Given this list of marker genes CNN1, MADD, LHX1, SLC9A7, ARHGAP6, HYCC2, WBP1L, NCKAP5, FNDC7, ATF3, ADGRL1, CREB3L3, GJB2, RAB3A, CNTN2, CIAO2A, PLPPR2, IDH3A, HP, CPNE1 (NCBI Gene Id 8904), NREP, TGM6 (NCBI Gene Id 343641), FBLN5, CDH6, OGDHL, OXA1L, PHB1, CLIC1, ARRDC1-AS1, BCKDHA, CDH13, RB1CC1, STAC2, ST8SIA5, NAE1, TPM3, TRMT10A, NRSN2, BTG2 (NCBI Gene Id 7832), CIART, SIK3, CALCB, SLC29A2, FOXD3, MTUS1, SGIP1, ANKRD28, CREB3, DENND2B, DUSP3, DIRAS1, FNDC5 (fibronectin type III domain containing 5), RUNX1T1, AFG3L2 (NCBI Gene Id 573970), SLC24A4, TTL, SELENOI, BZW2, ZMAT4 (NCBI Gene Id 79698), DAZAP1, KIRREL3-AS3, ACKR3, IL17A, PLA2G2E, FANCD2 (NCBI Gene Id 2177), MTTP, PITX2, COMTD1, TSC22D2, PPP1R16B, TMEFF1, HPN, KCTD6, RTN4R, CHCHD4, TRPM4, RFX5, ABR, TMEM50B, RPS14, ATP6V1A, TMEM71, ATP5F1C, COMMD3, JARID2, CFP, RS1, G0S2, VPS26C, SCUBE3, SIRPA, SLC31A2, MED13, FHDC1, INCA1, CHAT, TCF7, MARCKSL1, KCNE5, GRID2, SART3, NYAP1, SF3B4, WTAP, GRIA4, PRMT1, GEMIN7, HRH3, AMY2A, SDHD, ATP6AP2, BPNT2, BEND6, MREG, MYOM3, MFN1, CCNB1IP1, CSNK2A1 (NCBI Gene Id 1457), LINC00472, JPH2, EEF1G, TTC19, MEF2D, FSTL3, CCDC38, KCND3, MITF, TENM3-AS1, CNOT9, BMPR1B, PKN1, WNT4, PIEZO1, ESRRG, TIMM8B, FAM193B, PCSK2, CDKN1A, SH3RF2, HOXC13, TRMT2A, MLX, ATP1B1, HNF1B (HNF1 homeobox B), CYP21A2, AIFM3, UCHL1, MLST8 (MTOR associated protein, LST8 homolog), CDK14, BTBD3, TAB3, BNC2 (NCBI Gene Id 54796), VEZF1 (vascular endothelial zinc finger 1), MEIS2, PRDM9, VEGFA, HIPK2, SOX12, ANGPT1, RBPMS, ABHD17B (abhydrolase domain containing 17B, depalmitoylase), C1QTNF7, PACS1, SLC30A3, SLC22A11, CALHM1, MYL3, ZMAT3, SPATA32, NAA50, CYP39A1, ZSWIM1, TAFA1, ADAMTS14, CLTC, HIBADH, ERRFI1, ABHD8, RANBP1, CALCA, FAM81A, MRPL14, PPP3CC, TAGLN2 (transgelin 2), DAAM1, MAP1B (microtubule associated protein 1B), TMEM187, SAMD14, ADGRA2, DNAJB13, PPA1, ZFYVE9, SPAG8, RCOR2, RBMX, SMIM3, TPPP3, PRKAB1, SOD3, ACAT1, DNAJB8, ARHGAP18, EFNB2, HOXA5 (homeobox A5), NPAS2, MRPL47, KMT2E, SPATA3, RAPH1, LINC00487, RBM4B, MBD6, EEF1A2, ADAMTSL3, GABBR2, CRISPLD2, DCTN2, CCDC69 (NCBI Gene Id 26112), CHCHD10, ID3, COX5B, RAB6B, ALPG, FGFR3, MRPL2, PRLR, MYADM, OSM, POLR3D, DLX4, SOX4, UBQLN3 (ubiquilin 3), ZNF143, TMEM35A, SH3GL2, TNNI1, PACSIN1, C1orf116, NFIL3, RASGRP2 (RAS guanyl releasing protein 2), VTA1, LRCH4, SOCS2, TMEM135, SYNGR1, PRDM16, MROH5, VASP, SLITRK1, AAMP, TLX2, AGPS, NDFIP1, SUN5, PPM1B, TAOK2, DNAJC27 (NCBI Gene Id 51277), PKNOX2, HOXA3, ODAD3, C6orf47, C12orf50, ARX, MASP1, GTF2IRD1, RGS3, PPP2CA, MAPRE1, SNPH, SLC25A13 (solute carrier family 25 member 13), AK2, ASXL2, KCNK1, ACO2, SV2A, LCA5, SLC37A2, DNM1, YTHDF2, CSMD3, RXFP4 (relaxin family peptide/INSL5 receptor 4), APBA2, SEMA3F, GABRG2, MED26 (NCBI Gene Id 9441), PHF5A, NNAT, LDB3, NFIX, ARL8A, FSTL1, AP1S2, MFF, PNKD, RHOT1, FXYD1, MTX2, WDR82, ODF1, TBX6, RPE (ribulose-5-phosphate-3-epimerase), SLC27A4, ABCC5, TMCC1, ITPKA, IFRD1, PITPNM1, EWSAT1, MAP4K3, DOLK, AGAP2 (NCBI Gene Id 9809), AP1B1, HOXD3, RPP25L, SLC25A5, DNAI7, MYH13, SLCO3A1, ENSG00000291228, KIN, PSD3, CEND1, SEMA7A, TMEM196, NXPH4, SPATA31G1, EMC8, NEUROG2, TP53BP1, ST3GAL1, ATP5MK, KIF6, COA8, TF, GOT1, OAT, XPR1, PAX6, MRPL12 (mitochondrial ribosomal protein L12), ESAM, SPMIP6 (sperm microtubule inner protein 6), CHD2, MLLT6 (NCBI Gene Id 4302), ARHGEF12, ADAMTSL5, NDUFB5, GOLGA4, RTN3, UQCRC2, RNF4, DLX1, PPP1CB, TRAP1, ETV6 (NCBI Gene Id 4348), PRKCSH, MSI2, PHACTR3, UBE2D3, BAG5, EXTL2 (NCBI Gene Id 2135), LTBP3, NUFIP2, NTMT1, HCN1, HSALR1, ARHGEF38, ATP5MC3, GOSR1, KLC4, GRIK3, DIPK1B, FAM170A, CCDC9B, CDH20, ZFP91, R3HDM2, COPS7A, HMGB3, PDZK1, RPS6KA5, COX4I1, MPP2 (MAGUK p55 scaffold protein 2), ERGIC1, TBC1D22A, RAB11FIP5, SENP1, CLC, POU3F2, DTNB, CDC42EP1, DDIT3, S100A5, HS6ST2, SYT17, FHL3, ALDOA, DOK4, ILRUN, MEF2C, PALS2, CNTN6, TMEM161B, RIMS2, PANK1, NTNG2, TOMM70, MT-CO1, RTKN, KLHL41, AKAP1, EIF4E, BCL6, OR3A2, AUH, APP, THPO, PFN1, RNF121, GPATCH2L, AQP7, TUBB4A, DNAJC11, ANO4, RHO, ABL1, ZNF644, CLIC4, BAIAP2L2 (NCBI Gene Id 80115), TMEM43, MRPL34, TFRC, LAMTOR3, ZNF768 (NCBI Gene Id 79724), RHOG, CRABP2, CYTH2, ATP5MC2, LARP4, RNGTT (NCBI Gene Id 8732), OSGIN1, TBXAS1, STIM1, FBXL22, FBLN1, TPM2, SH2D2A, SYNPO, USP2, RCAN2, PIPOX, FBXW4, PARD6A, RFX1, CACNB2, C9orf85, PIP4K2A, AP2M1, SLC7A9, SCNM1, MBD5, AGAP3, ANGPTL8, PYGM, ADAM9, CCDC92, SORL1, RIN2 (NCBI Gene Id 54453), ETFRF1, PRRX2, KIRREL3, TMTC1, PDE1A, PPTC7, SPATA20, CRTAM, LRRC41, CBX6, CD86, VAMP1, USP37, ANK3, CRH (corticotropin releasing hormone), CIZ1, FOXA1, YWHAG, MAP1A, HOXA2, CLIP1, GFAP, SCN5A, SOX5, CNTLN, MBOAT2, TIMM44, OBSCN, YWHAH, SLC25A4, IL21R, NCOA6, BCL2L13, ARF3, USP51, SLC9A3, TSSK3, INSR (insulin receptor), LRRTM3, MSX1, RBMS1, CSRNP1, MYBPC2, MGST3, PCBP4, MPPED2, TRAK2, FGD2, POLD4, RPH3A, TEK, NDUFA3, LRPPRC, KCNG4, FGF12, CCNE1, UBAC1, CDK15, SPEM1, SLC31A1, CCDC106, KIAA0586, USP3, ISCU, DNAJA2, CNTN4, TLL2, EPS8L2, KLK15, DMRT2, RANBP10, ATP5F1B, SPAG9, PDIA3, F2, CTSD, WBP4, LINC01101, ATAT1, STK32A, MAEA, SLC16A6, HSPD1, ZSWIM3, FGG, ZRSR2, SLC16A13, ELF4, DHX35, HSPE1, ZNF775, TBC1D15, NR5A2, ZNF532, CNTFR, KCNN1, RADIL, HIGD1A, DLG2, MYL1, DPF3, ITGB6, CORO7, POU5F1, DEPDC7, SORCS1, CLUH, USP25, RNF139, CKB, MRPS21, ST3GAL5, SH2B3, PLA2G12A, PAX7, UBL3, PCSK5, ASXL1, RELL2, RRAGD, LTN1, PGF, ELAVL3, HOXC5, BLCAP, TBX5, TBL1XR1, CSRNP2, SLC4A3, ST8SIA1, GPR157, GNA13, MAP4K5, CLCN2, SLC10A7, MIR22HG, GABARAPL1, DGCR8, SMARCC2, COX8A, SATB1, NPTX2, LMO3, VAMP2, RABGGTB, ZIC4, BDNF, ASTN2, LMNTD1, CCBE1, ATP5PF, MRFAP1, RAB10, SLC6A9, NDUFA4L2 (NDUFA4 mitochondrial complex associated like 2), GPR162, NOG, ARFGAP2, ZNF687, NALF2, CD37, LINC00303, DCUN1D4, USP31, GREM1, YBX2, ZBTB40, MAL, RPS6KA2, NEFM (neurofilament medium chain), SLC16A8, JADE2, CAPN12, MPC2, SLC26A3, RPL32, CHMP2A (NCBI Gene Id 27243), WDR72, NR0B1, COLQ, PPM1E, SLC6A8, ABRA (actin binding Rho activating protein), ELAVL4, RGS7, GLI1, NEURL1, RAPGEF5, SRSF6, SLC26A6, TCF7L2, SYNGR3, IFFO1, HPCAL4, REM2, GABPA, DNER, HOXB3, KLK3, C1orf21, CEL, CYP1A1, RND3, LINC01089, TRIP10 (thyroid hormone receptor interactor 10), CGN, IQSEC1, RRBP1, GAPDH, CATSPER2, ENO3, NDUFA5, ACE2, MRPL37, CANX, KLHL36, SMPD1, KLF12, NCOA2, NKX6-3, UHRF2, HAS1, FH (NCBI Gene Id 83748), SAG, DCHS1, CDK13, H4C3, INPP5F, CXXC5, MRPS28, YY1AP1, TFEB, FABP3, WDFY3, ATP5MJ, MFAP5, IKZF2, PPARGC1A, SCAI, ATAD2, MARCHF1, PPP1CC, HOXA10, ESRRB, WDFY3-AS2, ACOT8, LYG2, ASIC1, RBFOX1, DCTN1, LAMB2, AMPD3, DMD, HPX, TIMM9 (NCBI Gene Id 26520), CLDN4, RREB1, MIDEAS, TIMM23, WDR81, RNF19B, AP5B1, STRADB (STE20 related adaptor beta), SERPINC1 (serpin family C member 1), NRP1, PLXND1, EPC2, SPATC1, TAOK3, CDH24, EDARADD, KCNN3, UQCRC1, ETFDH, LORICRIN, METAP1, TEX35, DNASE1, RHCG, NDUFB3, TMSB4XP4, SNTG1, TLN1, SCFD2, TMED4, IMMT, IRF2BPL, KCNQ1DN, DDB1, MROH7, OSR2, ABCF3, RAP1GAP, HSPA9 (NCBI Gene Id 91471), SAT1 (NCBI Gene Id 6303), CCSER2, HOXB5, SLC38A3, GBF1, RASSF1, FSIP2, ATP1A3, SLC25A27, NHERF1, TRERF1, CALU, TMEM38A, TNFRSF12A, DDIT4L, SDHB, KIF5B, LRFN4, UQCRH, HRC, STAT5A, ADAM15, CCL20, RARA, ABHD3 (NCBI Gene Id 90492), CDK16, KCNK5, GRM8, KRIT1, ATF6, FHL1, LCN2, KIF5A, HCN4, DMPK, GPR52, HOXD10 (homeobox D10), ITGB1BP2, SPTAN1, KCNIP2, DCT, ANXA9, PCDH7, C19orf18, CDKL5, NDRG2, ZBTB43 (zinc finger and BTB domain containing 43), CRTAC1, FGF7, TSPAN12, GPBP1L1, MTRES1, GPR55, CIPC, ATP6V1B1, LETM1, SCT, ZRANB1, MECOM, GFPT2, RHOQ, DLAT, PIM1, AGBL2, HTR1B, BCL9, CTNNA3, PBX4, BRAF, KCNMB3, CLDND1, ITGA7, BOC, SORT1, OTX1, FBXL5, KCNMB2, ZDHHC5, RPRD2, TPI1, BCAR3, FBXO30, ANPEP, OPHN1, SLC25A34, EMC3, NCDN, BNIP3 (NCBI Gene Id 664, BCL2 interacting protein 3), MT-ND1, NR2C2, NTF3, OARD1, CHGA, CNTF, CDCP2, CDH16, LRFN5, ST20-AS1, SLCO2A1, WDR77, SLC2A13, DGKI, EPN3, MNT, MDH1, GSE1, SLC25A3, NEK2, ABTB2, ATP5MC1, SHISA7, TMEM182, RAB22A, PRR7, MTCH2, WWC1, PRDM14, DENND2D, KANK4, NR1I2, CEP97, STEAP2, NFYA, RPL27A, ACR, TLCD5, TLR4, C6orf136, ILVBL, ELAVL1, SCNN1A, AHCYL1, NRXN1, SP8, HHATL, DHRS11, RAP1GAP2, FUT11, CUTA, XYLT1, TOMM40, IL11, SLC41A1, VSNL1, PLCXD2, ERBB4, PGAP2, BPIFA2, HSPB7, NRXN2, HTATSF1, MYF5, ADCY1, SHB, ALX4, GABRA3, SMARCA5, STMN1, TNXB, NEDD9, GLUD1, EPHA7, FAM162A, COX7B, TNNI3, GMFG, JMJD1C, APEX2, NFE2L1, PNMA8A, UGP2, SP2, PPP2R3A, MAST1, NIPSNAP1, GK, PABIR3, PNRC1, CASQ2, RP1L1, ZNF296, TM2D2, AOC2, RNF2, BEST3, GSTO2, CKMT1B, IRAG1, KIF1C, SRCIN1, COX14, PDHX, FGF9, GTPBP1, SMARCA1, CEBPB, DRAM2 (NCBI Gene Id 128338), LIFR, WNT10A, MCC, SMOC1, CSF2, ME3, FBXO24 (F-box protein 24), SMAD7, ATP5F1A, MANF, ATP6V0C, ESRRA, SIX6, SERINC2 (NCBI Gene Id 55431), TSPAN7, ELF3, STK38L, HECTD2, PNOC, CA2, PMEPA1, KCNH7, ZDHHC21, WWP1, DNMT3A, SLC2A4, RTP3, NIPSNAP2, ARF6, CDHR5, GDPD1, TAFAZZIN, BHLHE40, PPM1L, INO80, DCUN1D1, SPRY4 (NCBI Gene Id 81848), RBP3, CALM2, C7orf33, DACT1, MYLK, AMER1, CTDSPL2, CDC42BPA, LINC01567, MT-ND2, PIM3, VDAC2, NRAP, XYLT2, DIAPH1, BLTP3A, RPS4X, CAMK2G, SCAMP5, ZBTB33, CX3CL1, NKAIN3, KMT2A, OR10A5, KLF7, SIK2, LHX2, CYC1, AP1G2, FZD9, NRG1, AMPH, PGK1, HOXC10, TMEM270, UBA1, YTHDF3, TCERG1, UQCR10, KCNC1, UBE2K (NCBI Gene Id 84819), SAP18, FBH1, DEXI, DLK2, PRPSAP1, ARHGAP24, LUC7L3, CDC42EP3, GASK1B, TPM4, PRG2, JAKMIP2, PEX26, SDK1, ATP5PB, STAU1, PLEC, CDIN1, RNF14, NR2C1, LRP5, NACC2, RILP, LYSMD1, CSRNP3, CS, NAA25, AIFM1, FCHSD2, here is a description of the gene set: Genes having at least one occurrence of the highly conserved motif M25 TGACCTY in the regions spanning 4 kb centered on their transcription starting sites. This matches the ESRRA transcription factor binding site V$ERR1_Q2 (v7.4 TRANSFAC). Comprehensive identification of all functional elements encoded in the human genome is a fundamental need in biomedical research. Here, we present a comparative analysis of the human, mouse, rat and dog genomes to create a systematic catalogue of common regulatory motifs in promoters and 3' untranslated regions (3' UTRs). The promoter analysis yields 174 candidate motifs, including most previously known transcription-factor binding sites and 105 new motifs. The 3'-UTR analysis yields 106 motifs likely to be involved in post-transcriptional regulation. Nearly one-half are associated with microRNAs (miRNAs), leading to the discovery of many new miRNA genes and their likely target genes. Our results suggest that previous estimates of the number of human miRNA genes were low, and that miRNAs regulate at least 20% of human genes. The overall results provide a systematic view of gene regulation in the human, which will be refined as additional mammalian genomes become available. studied in species Homo sapiens Human Gene Set: TGACCTY_ERR1_Q2 from publication Xie X, Lu J, Kulbokas EJ, Golub TR, Mootha V, Lindblad-Toh K, Lander ES, Kellis M (PMID 15735639)